Given this list of marker genes PIK3R1, GNAO1 (G protein subunit alpha o1), MAPK11, ARRB1, DNM1, PDPK1, MAP2K1, MAP2K3, MAP2K2, RICTOR, CXCL10, MAP2K6, GNAI2, GNB1, AKT1, CXCL9, MTOR, HRAS, NRAS, PIK3CA, MAPKAP1, SRC, PF4, GNAI3, GNAZ (G protein subunit alpha z), CXCL11, PIK3CD, MAPK14 (mitogen-activated protein kinase 14), CCL11, MLST8, KRAS, GNAI1, MAPK1, MAPK3 (mitogen-activated protein kinase 3), ITGAL, GNG2, ITGB2, CXCR3, RAF1, PIK3R3, PIK3R2, CXCL13, PIK3CB, here is a description of the gene set: studied in species Homo sapiens Human Gene Set: PID_CXCR3_PATHWAY CXCR3-mediated signaling events from publication Schaefer CF, Anthony K, Krupa S, Buchoff J, Day M, Hannay T, Buetow KH (PMID 18832364)